The following is a description of a gene set: from publication Moreaux J, Cremer FW, Reme T, Raab M, Mahtouk K, Kaukel P, Pantesco V, De Vos J, Jourdan E, Jauch A, Legouffe E, Moos M, Fiol G, Goldschmidt H, Rossi JF, Hose D, Klein B (PMID 15827134) Up-regulated genes distinguishing in multiple myeloma (MM) samples with higher expression of TACI. Human Gene Set: MOREAUX_MULTIPLE_MYELOMA_BY_TACI_UP B-cell activating factor (BAFF) and a proliferation-inducing ligand (APRIL) have been shown to promote multiple myeloma (MM) cell growth. We show that the main site of production for BAFF and APRIL is the bone marrow (BM) environment, and that production is mainly by monocytes and neutrophils. In addition, osteoclasts produce very high levels of APRIL, unlike BM stromal cells. Myeloma cells (MMCs) express TACI (transmembrane activator and calcium modulator and cyclophilin ligand interactor), the receptor of BAFF/APRIL, at varying levels. TACI expression is a good indicator of a BAFF-binding receptor. Expression data of purified MMCs from 65 newly diagnosed patients have been generated using Affymetrix microarrays and were analyzed by supervised clustering of groups with higher (TACI(hi)) versus lower (TACI(lo)) TACI expression levels. Patients in the TACI(lo) group had clinical parameters associated with bad prognosis. A set of genes was differentially expressed between TACI(hi) and TACI(lo) MMCs. This set makes it possible to efficiently classify TACI(hi) and TACI(lo) MMCs in an independent cohort of 40 patients. TACI(hi) MMCs displayed a mature plasma cell gene signature, indicating dependence on the BM environment. In contrast, the TACI(lo) group had a gene signature of plasmablasts, suggesting an attenuated dependence on the BM environment. Taken together, our findings suggest using gene expression profiling to identify the group of patients who might benefit most from treatment with BAFF/APRIL inhibitors. species: Homo sapiens, and this is the list of marker genes: MAST4, REM1, GRB10, CIDEC, ENTREP1, MPP3, GIT1, NOCT, F7, LRMDA, NOP56, OLAH, FMOD (fibromodulin), AZGP1, PCDH11X, ARG1, ANKRD26, CD80, PYGL, CACNA1I, NAP1L1, HAMP, CCDC33, CAMK2B, FOXF2, DDR1, RPS6KA4, TUT1, PIK3R2, KCNB1, AMN, VDR, FLRT2, SSTR2, SLC12A3, HLA-DMB, GZMB, GJB3, PTCRA, LINC02574, RNASET2 (NCBI Gene Id 8635), PLXNA1 (NCBI Gene Id 84202), RNF122, PI16, GP1BA, RBM38, PICK1, PTBP3, ULBP1, RAB11FIP5, NOXA1, ADH1A, GNA11, LIMA1, LDHAL6B, SYNGR1, AAK1, GGTA1, MOSPD3, SZRD1, MASP2, FXYD2, PDGFB, TNFRSF13B, API5 (NCBI Gene Id 95494), CEACAM5, LUZP1, CD22, PIWIL2, EPB41L1, GSTA4, ACAA2, CDK13, EFHC2, CEACAM6, SAA4, TIFAB, CRYM, ERCC2, PGAP4, TMPRSS11D, MIR9-1HG, RPL6P17 (ribosomal protein L6 pseudogene 17), ALPL, BTG2-DT, ROS1, CLEC4M, COX6A2, MMRN2, POFUT2, SASH1, HOXA6, SIGLEC7, INF2, MYZAP (NCBI Gene Id 100820829), NRP2, MIR23AHG, ATP1B4, KMT5C, SNCA, SLC6A13, NPPA, DUSP8, VASP, LRRC41, NRG1, DUSP3, OR2C1, RNASE1, CALB2, BTN1A1, PLA2G5, SCRG1, RAB11B, ACRV1, NEUROD2, SLC6A5, MAMLD1, PIK3CD, KIAA0586, LCN10, MOB3A, RABEP2, SMIM10L2A, MCM8, GPR12 (NCBI Gene Id 283535), GNA15, PLAUR, PIK3R5, EEF1A2, CNMD, PKP2, PBX2, TNF, SGSM2, DNAI4, SNAPC2, ARHGEF16 (Rho guanine nucleotide exchange factor 16), ETV7, RPGRIP1, DAO, CDC5L, HPCAL4, CHST4, BTNL3, CTXND1, NPEPL1 (NCBI Gene Id 79716), CEBPA-DT, CDC42EP4, SCN10A, PCDH1 (protocadherin 1), RHPN1, BPIFA1, USP27X-DT, NUAK1, SNTA1, PRX, GNG2, SCNN1A, APAF1, SNN, MXRA8, PTGES, AFDN, HMGA1P4, RIN1, ACTN2, TCEAL2, NECTIN2, ETV1 (NCBI Gene Id 221810), GPR27, ACTB, CHRNA6, STRA6, RIPPLY3, CEACAM1, MRPL28, TNFAIP6, B4GALT1, HS3ST2, TCP10L, CAPS, SAMD14, KLF2, ADCY10, PMP2, IGKC, ZNF263, ALPP, EPHB6, TACR1, PDE3B, CAMK1G, HUS1, HTR4, IL22RA1, TMEM40, ARHGAP44, SEMA4G, POU2F2, KCNK10, SYCP2, SPACA4, ATL2, MITF, MRC2, C3AR1, HLCS, MBP, OR1E3, GRM7, MAPK14, OR2H2, PRR15L, RAB11FIP1, KCNH2, OR1F1, ARRB1, SLC1A7, HORMAD2, MMP14, CLDN10, TRIM48, SPEF1, TRPV1, NCR2, SPAG8, TRMT61A, EPHB4, HYI, BIK, KIF5A, ANXA8, AKAP7 (A-kinase anchoring protein 7), RPL18, BIRC7, PLLP, NMT2, WIPI2, MIR3147HG, DNAJB5, DUSP9, HMGA2, SHANK2, FA2H, PKNOX2, GLG1, AKR1C1, TSNAXIP1, NF1, ARL4D, MAPK1, CTRB2, NEURL1, CR1, NTRK3, DDAH2, VGLL3 (vestigial like family member 3), GLP1R, CYP11B1, TRIOBP, TOR4A, COL11A2, B3GNT4, SPATA2L (NCBI Gene Id 124044), TULP1, C6orf47, DMTN, GCHFR, CIBAR1, MTA1, ITPKC, ENSG00000301105, PINK1, AMPH, LBH (LBH regulator of WNT signaling pathway), CTAGE9, FXYD3, LINC03100, PIN4, STYK1, MPP2, LMNA (lamin A/C), DDIT3, VENTXP1, CASZ1, BRD3OS, ZNF324B, TUBB2B, ACAD10, NCR1, MAPK8IP2, OASL, TAAR2, LPAR1, FBXO9, SYT12, CNR2, LGALS8, MYBPC1, ADAM11, TMEM63A, IKZF4, DOK1, KCNIP1, GABBR1, S100A12, PHF1, IMPDH1, PPFIA3, LRRC15, ARHGEF15, PQBP1, ITGA2B, SLC6A8, MSC, SOX12, NACC1, KHSRP, RGS12, ASH1L, PBX2P1, ADARB1, CCNP, ARFRP1, GSTM5, MEF2D, SYDE1, SGSM3, IL18BP, CXCL1, ALDH3B1, CCR6 (NCBI Gene Id 1235), AMELX, ZNF362, CFC1, MAP2K3, KLK13, CEP170B, TNFRSF8 (NCBI Gene Id 943), GNG4, SLC22A14, HRK, SEMA3F, P2RY4, CAPN5, NR4A1 (NCBI Gene Id 93352), FURIN, FMO2, DMC1, LTBP2, MGC16275, MLPH, RPL37A, DDX54, ODAD3 (outer dynein arm docking complex subunit 3), CELA2B, ACSL6 (NCBI Gene Id 56972), CDKN2B-AS1, C1QL1, ATP2C2 (NCBI Gene Id 9914), BEX1 (NCBI Gene Id 55859), ABCG4, NQO1, NIPAL2, LAIR2, HSPA6, DRD5, GNAQ, PML, DSP, FADS2, MTSS1, ROBO4, NOS1